The following is a description of a gene set: Mouse Gene Set: GOBP_REGULATION_OF_PHOSPHATIDYLCHOLINE_METABOLIC_PROCESS species: Mus musculus Any process that modulates the frequency, rate or extent of phosphatidylcholine metabolic process., and this is the list of marker genes: Rab38, Scarb1, Acsl3, Ldlr, Fabp3, Capn2, Apoc1, Mfsd2a, Abca3, Lpcat1